The following is a description of a gene set: species: Homo sapiens Ub-specific processing proteases Human Gene Set: REACTOME_UB_SPECIFIC_PROCESSING_PROTEASES, and this is the list of marker genes: H2BC5, H2AC16, PSMA6, H2BC14, USP17L21 (ubiquitin specific peptidase 17 like family member 21), TRRAP, H2BC8, SKP2, MYC, DDB2, AXIN1, RIPK1, PSMD8, PSMC1, TNKS, PSMC4, TP53 (tumor protein p53), H2AC13, PTEN, CCNA1, USP3, MDM4, MDM2, WDR20, MUL1, PSMA4 (NCBI Gene Id 5685), H2AC11, TADA3, USP17L24, H2AC15, USP17L3, IFIH1, RHOT1, SUDS3, PSMD11, USP17L17, USP17L28, PSMD7, USP16, USP17L15, USP17L27, SIAH2, USP17L20, SMAD3, PTRH2, TGFBR1, CDC20, USP12, USP24, USP17L29, USP18, ATXN7, H2AC21, H2BC6, VDAC1, UBC, USP9X, MAP3K7, H2BC3, USP8, CDC25A, RNF146 (NCBI Gene Id 81847), H2BC4, PSMB4, H2AC25, USP5, USP17L10, USP17L2, TNKS2, USP26, USP2, PSMD14, PSMD2, USP17L22, TRAF2 (TNF receptor associated factor 2), USP17L5, PSMA7, USP34, USP4, RUVBL1, H2AC1, H2AC7, H2BC12 (H2B clustered histone 12), GATA3, UBA52, NFKBIA, IKBKG, FKBP8, VDAC3, PSMD12, H2BC13, USP15, UFD1, SMURF2, USP14, H2BC7, SEM1, ADRM1, H2BC15, USP17L4, H2AC4, H2AC6, USP17L11, BECN1, OTUB1, USP11, TRAF6, WDR48, USP17L18, USP33, HGS, PSMD1, IDE (insulin degrading enzyme), PSMA2, H2BC18, TAF9B, H2AC12, MAT2B, USP17L12, IL33, PSMC3, USP19, USP13, USP17L13, H2BC17, VDAC2, USP17L30, USP20, SMAD7, PSMC5, HIF1A, PSMA5, PSMB5, RIGI, PSMB3, ARRB1, USP49, H2AC18, RNF128, H2BC26, ARRB2, KEAP1, CCNA2, KAT2A, CFTR, ADRB2, USP17L19 (NCBI Gene Id 100287404), USP22, USP17L26, UBB, BIRC2, H2BC10, H2AC20 (H2A clustered histone 20), SMAD4, H2AC14, H2BC11, TOMM20 (NCBI Gene Id 9804), USP17L8, PSMD3, RPS27A, RCE1, PSMC6 (proteasome 26S subunit, ATPase 6), TAF10, USP37, USP44, H2BC1, RNF123, USP7, SMAD1, USP17L25, USP17L1, H2AC8, PSMC2, PSMB1, USP25, H2BC21, TAB1, USP42, TADA2B, BIRC3, H2AC17, H2AC19, POLB, PSMB2, H2BC9, USP48, USP10, PSMB6 (proteasome 20S subunit beta 6), PSMA3, USP21, PSMD13, CLSPN, CYLD, SMAD2, AR, PSMD6, USP47, PSMA1, PSMB7, TOMM70, CCP110, SNX3, USP30 (NCBI Gene Id 84749), STAM2, AXIN2, USP28, FOXO4